The following is a description of a gene set: The progression of a connective tissue over time, from its formation to the mature structure. studied in species Mus musculus Mouse Gene Set: GOBP_CONNECTIVE_TISSUE_DEVELOPMENT, and this is the list of marker genes: Prrx2, Slc26a2, Guca2b, Axin2 (NCBI Gene Id 12006), Osr1, Foxd1, Ctsk, Gli3, Eif2ak3, Matn3, Bmp2, Bbs2, Six2, Bmp6, Egr1, Ubb, Il17f, Pdgfd, Hoxa11, Pth1r, Fosl2, Col5a1, Nr1h4, Bmp10, Trpm4 (transient receptor potential cation channel, subfamily M, member 4), Sox6, Fbxw4, Creb3l2, Sox5, Cytl1, Rb1, Pum2, Ap1s2, Sox9, Bgn, Ep300, Ccn1, Lox, Glg1, Osr2, Tgfbr1, Ccn3, Acta2 (NCBI Gene Id 68377), Cd2ap, Ltbp3, Large1, Pkd1, Hes5, Wnt9a, Grem1, Poc1a, Vps13b, Pkdcc, Plaat3 (phospholipase A and acyltransferase 3), Hmgcs2, Ppard, Nkx3-2, Arid5a, Galnt3, Ctnnb1, Sh3pxd2b, Ccn4, Col6a1, Pdgfa, Epyc, Bmpr2, Fgf9 (fibroblast growth factor 9), Spart, Pgrmc2, Sik3, Maf, Adrm1, Fkrp, Wnt7b (NCBI Gene Id 22422), Zmpste24, Sirt1, Zbtb16, Hoxa3, Prkaa1, Mir140, Trip11, Gpr82, Mir103-1, Mmp13, Ddrgk1, Lep, Srf, Bmp5, Hand2, Ccn2, Selenom, Chrdl2, Hand1, Col1a1, Cbs, Msx2, Otor, Tgfbi, Evc, Gdf7, Ecm1, Sulf2, Mdk, Nog, Paxip1, Slc25a25, Dmd, Fgl1 (NCBI Gene Id 234199), Chaserr, Fgf18, Smad1, Gata3, Pitx1, Hyal1, Mkx, Gm15290 (NCBI Gene Id 102636218), Pth, Pik3ca, Chadl, Mir103-2 (microRNA 103-2), Msx1, Igf1, Csgalnact1, Kat2a, Stc1, Prrx1, Abhd15, Runx2, Rflnb, Bbs4, Timp1, Nfatc2, Sulf1, Ogn (osteoglycin), Edn1, Rasal2, Cst5, Mycn (v-myc avian myelocytomatosis viral related oncogene, neuroblastoma derived), Tgfb2, Cd34, Por, Hspg2, Hyal3, Sox8, Zfp516, Hoxd11, Ghrl, Scx, Cr2, Id4, Twsg1, Pdgfb, Amer1, Shox2, Gli2, Mef2c, Rela, Hoxd3, Tgfb1, Mex3c, Carm1, Lrp5, Ifrd2, Ppargc1a, Mkks, Gpr4, Fto, Mustn1, Xbp1, Smad3, Efemp1, Zfp219, Rflna, Pdgfrb (NCBI Gene Id 18596), Col9a1, Fgfr1, Lrp6, Hoxb3, Hif1a, Bmp4, Ihh, Gdf5, Bmp1, Thbs3, Tbl1xr1, Hsd17b1 (hydroxysteroid (17-beta) dehydrogenase 1), Errfi1, Loxl2, Tyms, Runx1, Runx3, Lipa, Chsy1, Col3a1, Il6ra, Spi1, Creb5, Asnsd1, Col11a1, Id2, Col2a1, Slc39a13, Hyal2, Adamts7, Hoxc4, Bmp8a, Sptlc2, Lmna, Lnpk, Dicer1, Arid5b, Foxa1, Wt1, Pparg, Mapk3, Hoxa5, Acat1, Dhrs7b, Nfib, Ptpn11, Hmga2, Umodl1, Gnas, Trps1, Atf2, Bmp3, Bltp1, Nfia (NCBI Gene Id 68838), Dgat2, Pax7, Bmpr1a, Nmnat1, Thra, Smad7, Rarb (retinoic acid receptor, beta), Arrdc3, Norad, Nr5a2, Fgfr3, Foxc2, Pbxip1, Snorc, Wnt2b, Bmp8b, Comp, Hras, Barx2, Optc, Frzb (frizzled-related protein), Rorc, Ncoa2, Tgfbr2, Wnt5a, Esrra, Ext1, Mir143, Fgf4, Bmpr1b, Parp1, Gdf6, Casr, Ncoa1, Gdf2, Satb2, Rspo2, Wnt7a, Ror2, Ext2, Myf5, Serpinb7, Dlx2, Slc39a14, Bmp7, Rxfp1, Col10a1, Chst11 (NCBI Gene Id 68647), Nppc, Gpld1, Snx19, Trpv4, Fgf2, Mia3, Cfh, Csf1, Pou4f2, Bbs1, Tapt1, Pthlh, Lpl, Npr2, Dyrk1b, Smad5, Itgb3 (NCBI Gene Id 268495), Thrb, Rara, Bpnt2, Sorl1, Scube2, Snai1, Col11a2, Cnmd (NCBI Gene Id 16840), Itgb8, Dspp, Scin, Foxa2, Col27a1, Ifng, Thbs1, Ift80, Idua (NCBI Gene Id 269679), Prkg2, C3ar1, Enpp1, Uncx, Atp7a, Cer1, Fgf6, Notch1, Rarg, Smad9, Snai2, Zeb1, Lncpint, Mboat2, Klf7, Wnt10b (NCBI Gene Id 22410), Acan, Serpinh1, Mef2d, Ifrd1 (NCBI Gene Id 15982), Sfrp2, Matn1, Mgp, Adamts12, Ebf2, Cflar, Prkca (protein kinase C, alpha), Bscl2, Smpd3, Mapk14, Zbtb7a